The following is a description of a gene set: part of: MAPK family signaling cascades Reactome Pathway: MAPK6/MAPK4 signaling studied in species Homo sapiens MAPK6 and MAPK4 (also known as ERK3 and ERK4) are vertebrate-specific atypical MAP kinases. Atypical MAPK are less well characterized than their conventional counterparts, and are generally classified as such based on their lack of activation by MAPKK family members. Unlike the conventional MAPK proteins, which contain a Thr-X-Tyr motif in the activation loop, MAPK6 and 4 have a single Ser-Glu-Gly phospho-acceptor motif. MAPK6 is also distinct in being an unstable kinase, whose turnover is mediated by ubiquitin-dependent degradation. The biological functions and pathways governing MAPK6 and 4 are not well established. MAPK6 and 4 are phosphorylated downstream of class I p21 activated kinases (PAKs) in a RAC- or CDC42-dependent manner. One of the only well established substrates of MAPK6 and 4 is MAPKAPK5, which contributes to cell motility by promoting the HSBP1-dependent rearrangement of F-actin. The atypical MAPKs also contribute to cell motility and invasiveness through the NCOA3:ETV4-dependent regulation of MMP gene expression. Both of these pathways may be misregulated in human cancers, and this is the list of marker genes: PSMD14, PSMB4, PSMD1, NCOA3 (NCBI Gene Id 8202), AGO4, PAK2, PSMA3, CDC42EP5, PSMB1, IGF2BP1, XPO1, MAPK6, PSMA4, MIR34B, KALRN, RAG1, CDK1, PSMB3, CDC42EP2, PSMB2, RAG2, UBC, CDC14B, UBA52, DNAJB1, PRKACA, PSMD6, AGO3, PAK1, PSMC1, CCND3, PSMA2, PSMC5, PRKACB, AGO1 (NCBI Gene Id 26523), PAK3, TNRC6B, PSMD8, MAPK4, SEPTIN7, TNRC6A, PSMD11, PSMB7, PSMD3 (NCBI Gene Id 94019), PSMA5, SEM1, HSPB1, AGO2, PSMD13, MAPKAPK5, JUN, MMP2, MIR34C, PSMB5, PSMD2, ETV4, PSMA6, PSMD12, PSMA1, CDC14A, PSMB6, FOXO3, PRKACG, MYC, UBB, FOXO1, PSMC4, CDC42EP3, PSMD7, RAC1, CDC42, PSMC2, RPS27A (NCBI Gene Id 6233), PSMA7, MOV10 (Mov10 RNA helicase), TNRC6C, PSMC3, PSMC6, ADRM1 (NCBI Gene Id 11047), MMP10